The following is a description of a gene set: from publication Purwin TJ, Caksa S, Sacan A, Capparelli C, Aplin AE (PMID 37636077) Human Gene Set: PURWIN_A375_SOX10_TARGETS SOX10 is a transcription factor involved with neural crest development and is expressed in cutaneous melanoma. Loss of SOX10 in cutaneous melanoma has been linked to an invasive phenotype as well as resistance to MAPK targeted therapies. Transcriptomic changes due to SOX10 loss was modeled using RNA-seq data from CRISPR knockout in A375 and MeWo melanoma cell lines. Signature genes were generated from the intersect of ChIP-seq target genes and significantly (BHFDR < 0.05) down-regulated genes. species: Homo sapiens Genes with a SOX10 ChIP-seq peak in the promoter region that are commonly down-regulated (BHFDR < 0.05) in two A375 CRISPR SOX10 knockout clones., and this is the list of marker genes: BCOR, SLCO4A1, BTBD3, TRAF3IP2-AS1, LINC00327, OSBPL10, NOCT, CHAMP1, GAS7, WDR82, ADGRG6, ETS1, FAN1, TNFRSF19, LRATD2, NDE1, ACSS1, NFIB, TTLL4, ERBB3, ZC3H7A, ANKRD28, USP6NL, NEDD9, PLA2G7, CDK2AP1, ZEB2, CSRP2, OPHN1, PCBP1-AS1, TBC1D16 (NCBI Gene Id 54493), RUBCNL, RAPGEF5, PRR7-AS1, RHOJ, NES, H1-9P, RNF145, S1PR2, PCAT1, PHGDH (NCBI Gene Id 94672), NPAT, SOX5, MGAM2, ST6GAL1, CD96, MIA, MMACHC, LINC00511, DNMT1, NOTCH4, FGD4, CDH19, ATP11A, NHSL1